Given this list of marker genes DMC1, TCFL5, SERPINB2, PNLIPRP2, NUPR1, MACROD1, ITGA4, TRIB3, RBM45, here is a description of the gene set: Human Gene Set: VANLOO_SP3_TARGETS_UP Mice lacking the zinc finger transcription factor specificity protein 3 (Sp3) die prenatally in the C57BL/6 background. To elucidate the cause of mortality we analyzed the potential role of Sp3 in embryonic heart development. Sp3 null hearts display defective looping at embryonic day 10.5 (E10.5), and at E14.5 the Sp3 null mutants have developed a range of severe cardiac malformations. In an attempt to position Sp3 in the cardiac developmental hierarchy, we analyzed the expression patterns of >15 marker genes in Sp3 null hearts. Expression of cardiac ankyrin repeat protein (Carp) was downregulated prematurely after E12.5, while expression of the other marker genes was not affected. Chromatin immunoprecipitation analysis revealed that Sp3 is bound to the Carp promoter region in vivo. Microarray analysis indicates that small-molecule metabolism and cell-cell interactions are the most significantly affected biological processes in E12.5 Sp3 null myocardium. Since the epicardium showed distension from the myocardium, we studied expression of Wt1, a marker for epicardial cells. Wt1 expression was diminished in epicardium-derived cells in the myocardium of Sp3 null hearts. We conclude that Sp3 is required for normal cardiac development and suggest that it has a crucial role in myocardial differentiation. species: Mus musculus from publication van Loo PF, Mahtab EA, Wisse LJ, Hou J, Grosveld F, Suske G, Philipsen S, Gittenberger-de Groot AC (PMID 17923686) Genes up-regulated in E12.5 hearts from mice with SP3 knockout compared to the wild type organ.